The following is a description of a gene set: species: Mus musculus electronically inferred by orthology from the curated human pathway This event has been computationally inferred from an event that has been demonstrated in another species.<p>The inference is based on the homology mapping from PANTHER. Briefly, reactions for which all involved PhysicalEntities (in input, output and catalyst) have a mapped orthologue/paralogue (for complexes at least 75% of components must have a mapping) are inferred to the other species. part of: Generic Transcription Pathway Reactome Pathway: Transcriptional Regulation by TP53, and this is the list of marker genes: Ppp2r1b, Polr2a, G6pdx, Tbp, Higd1c, Bax, Ccnh, Ywhae, Map2k6, Daxx, Mbd3 (methyl-CpG binding domain protein 3), Brca1, Ywhah, Igfbp3, Ccnb1, Zfp420, Aurkb, Npm1, Mapk14, Pip4k2c, Blm, Polr2k, Cox7a1, Rfc3, Ctdp1, Mapk11, Taf13, Ep300, Trp73, Gls2, Polr2f, Rabggta, Cox8a, Cdkn1a, Supt5, Nbn (NCBI Gene Id 27354), Prmt5, Taf5, Pip4p1, Cox7c, Taf8, Lamtor5, Triap1, Ppp1r13l, Rbbp4, Cox8c, Taf10, Cox4i1 (cytochrome c oxidase subunit 4I1), Pcna, Polr2l, Prkag1, Cdk1, Ndufa4, Rpa1, Gtf2f1, Rheb, Rabggtb, Taf15, Polr2e, Cnot7, Cdk13, Supt16, E2f7, Pou4f2, Taf7l, Cox7a2l, Ubb, Trp63, Cdc25c, Cox5a, Prdx1, Cradd, Lamtor2, Gtf2f2, Tnks1bp1, Nelfa, Tsc1, Nuak1 (NUAK family, SNF1-like kinase, 1), Sesn2, Ccne1, Taf12, Cenpj, Lamtor1, Tpx2, Gtf2h2, Ing2, Prelid1, Zfp385a, Dna2 (DNA replication helicase/nuclease 2), Bard1, Plk2, Cnot4, Polr2b, Brpf1, Cdk12, Banp, Phf20, Taf1, Rictor, Sfn, Ercc3, Brpf3, Taf7, Nelfe, Polr2c, Cox6a1, Gpx2, Cnot10, Taf11, Tcea1 (transcription elongation factor A (SII) 1), Trp53, Taf9b, Prdx5, Ccng1, Casp2, Ccne2, Csnk2b, Gadd45a, Chek2, Taf6, Ddit4, Supt4a, Gtf2h4, Ppp1r13b, Wrn, Kat5, Ehmt1, Mre11a, Cdk5, Cdkn1b, Steap3, Rps27a, Cycs, Sgk1, Txn1, Prkag3, Cox6c, Top3a, Rraga, Rad1, Pdpk1, Dyrk2, Lamtor4, Taf4b (TATA-box binding protein associated factor 4b), Mapkapk5, Cox4i2, Hus1, Polr2i, Rbbp7, Rad9a, Ccna1, Ercc2, Mta2, Rragc, Txnrd1 (thioredoxin reductase 1), Cox6a2, Rbbp8